Given this list of marker genes Nedd4, Zdhhc7, Ncoa1, Phb1, Ube3a, Mapk1 (NCBI Gene Id 98012), Wbp2, Ubr5, Src, Errfi1, Pgr, Klf9, Trerf1, here is a description of the gene set: Mouse Gene Set: GOBP_PROGESTERONE_RECEPTOR_SIGNALING_PATHWAY A nuclear receptor-mediated signaling pathway initiated by a progesterone binding to an intracellular receptor of the nuclear receptor protein family, and ending with regulation of a downstream cellular process, e.g. transcription. species: Mus musculus